The following is a description of a gene set: Human Gene Set: GSE2128_C57BL6_VS_NOD_THYMOCYTE_MIMETOPE_NEGATIVE_SELECTION_UP Fetal thymic organ culture (FTOC) DC2.5 CD4+CD8+ thymocytes from B6g7 or NOD background. 0 or 16 hour after addition of the BDC mimitope species: Homo sapiens Genes up-regulated in C57BL6 CD4 CD8 double positive thymocyte transgenic for the BDC2.5 TCR incubated with mimetope negative sel 16h versus NOD CD4 CD8 double positive thymocyte transgenic for the BDC2.5 TCR incubated with mimetope negative sel 16h. from publication Zucchelli S, Holler P, Yamagata T, Roy M, Benoist C, Mathis D (PMID 15780994), and this is the list of marker genes: MAOA, GLIPR1L1, EXOC6, SMPD5, CAP2, PIF1, CES3, ACRV1, NLE1, IL17RB, LYZL4, ELOVL3, HTR3B, C17orf58, CNTN2, ALKBH6, GGT7, GLI1, OIP5, PLCD3, WDR73, FGF2, SCG2, RAP1GAP, NUP42, ST6GALNAC5, KIAA0825, GAL, CENPB, IKZF2, ANKRD52, VMP1, AKR1C3, FUT10, ELFN1, SELE, ELN, INO80E, GRIN3A, CEP128, EFHC2, SAXO2, KRT80, EREG, DNASE1L3, NPL, TNN, FAM110C, GRPR (NCBI Gene Id 2925), TMEM141, PRODH2, FBXO17, ATG4C, RABL2A, SBSN, THAP6, GJA4, C17orf50, CBL (NCBI Gene Id 867), POMT2, OLFML1, DCLK2, FAM163A, ADAD1, TRPM1, PCDHB13, HDAC9, ANKLE1, ENPP2, XCR1, KLF1, PHACTR1, CLTB, GSTM4, TSPAN1, CABCOCO1, INSYN2B, EEPD1, ZNF483, SNX24, PPP6R2 (protein phosphatase 6 regulatory subunit 2), PARP2, CSF2, KLHDC10 (kelch domain containing 10), POMGNT1, GBX1, LCA5L, HTRA2, LY6D, RSPH9, S100G, ANGPTL6, APOLD1 (apolipoprotein L domain containing 1), SYNPO2, KIRREL1, ASPHD1, SLC25A31 (NCBI Gene Id 83447), KLKB1, MED27, NAA10, WDR31, OTOS, SLC26A4, SEC14L5, TUSC1, OR13J1, SNED1, MYBPC2, HES3 (hes family bHLH transcription factor 3), MPV17L2, FZD7, FABP3, ATP6V1B1, ABCC9, INSM2, DMP1, GPR182, IZUMO4, CNNM4 (cyclin and CBS domain divalent metal cation transport mediator 4), PIM2, CBLN2, SULT6B1, GUCY1B1, BMP7, ACBD4, NDUFA10, MTIF3, ANK3, WIF1, LRRC27, PGPEP1, TDRD12, CH25H, CADPS, C10orf120, IGFBP3, OR2S2, CHCHD6, SUSD5, DAO, GRHPR, SNHG7, OTOG, IL33, SLC2A2, CNN3, TRIM17, HOMER2, GAD2, MYOG, FGF5, UBL4A (ubiquitin like 4A), RABEPK, SMIM17, SLC46A1, TMPRSS11E, ACAP3, SNTB1, GHRHR, TMEM231, NUBP1, NMU, SORCS2, SCEL, RGR, ACVR2A, NKX1-2, F13A1, ITGB5, EVX2, LAGE3, POLRMT, TINF2, SASH1, GAL3ST2, RFTN2, PTPRT, XDH, FETUB, NIPSNAP1, BBS7, BEX4, NUP133, CHST4, ACY3, CDX2, C11orf71, NAGK, GRIA2 (glutamate ionotropic receptor AMPA type subunit 2), KCNT1, POSTN, CELSR3, SOCS1, ARHGAP23 (Rho GTPase activating protein 23), KEAP1, DRG1, MYO19, BBS2